Given this list of marker genes PRKAR1B-AS1, C9orf152, MARCHF4, ADAM32, SLC8A3, F5, PLXNB3, PKHD1L1, LINC02284, ADRA2A, P2RY1, CHRFAM7A, GRM3, DNAAF4-CCPG1, ZFP3, ZNF234, GTF2E1, AP1G2-AS1, EREG, TCEAL1, MFAP3L, ZNF543, LINC01331, IL5RA, FKBP1B, WFDC10B, ZNF425, SEPTIN5, INPP5E, CFAP58, INAFM2, RAB27B, MPIG6B, LINC02916 (NCBI Gene Id 124902415), SLC37A1, MMRN1, TNNI3, ACTR5, UPK1A-AS1, MLIP, EFHC2 (EF-hand domain containing 2), PTGS1, RPS6KL1, GP6, RBPMS2, ANKRD20A11P, GK-IT1, CENPS, EGF, PTCRA, PF4, RPL7P7, ANKRD62, EHD3, PTPRK-AS1, MYOM1, LIPC-AS1, ZNF852, PIP5K1C, EFCAB13, EEF2KMT, HOXB-AS2, CLDN2, SUCNR1 (succinate receptor 1), DGKG, LINC01141, ALOX12, TMEM40, ENSG00000227355, NXT2, ITGA2B, ERICH6, RPL31P52 (ribosomal protein L31 pseudogene 52), CNST, RN7SKP16, PCYT1B, PDE6A, ASB2, XYLT2, KLF9, RYR3 (ryanodine receptor 3), NT5M, COL24A1, RAB3C, GP9, ZG16B, RBM15-AS1, PIGP, EYS, LY6G6F, MED12L, CMTM2, MAST1, FAM186B, XIRP2, PEX5, LGALSL, FMO5, TM7SF3-AS1, ABCC3, DGKI, GP1BA, LATS2-AS1, KIAA0513, PRKAR2B-AS1, HPSE, GABRE, PPIF, ITGB3, H2BC4, LINC01786, PTPN23-DT, MLYCD (malonyl-CoA decarboxylase), NRGN, CDK9, LEFTY1 (left-right determination factor 1), LINC01123, PPBP, MTURN, TUBA8, DPY19L2P1, CAPN1-AS1, INTS5, DNAH10, GCSAML, PSPHP1, XRCC2, LINC00534, EXOC3L4, ZNF32, CMTM5, KCNH6, TUBB1, CLEC1B, PADI4, RUFY1, SRPRB, EXOSC5, CXCL3, YTHDF3-DT, SLC39A3, TXNL4B, SELP, RNU6-1228P, PLAC9P1, INHBA-AS1, TTC4, LINC02267, RNU6-469P, MYH7B, ST8SIA6, RNU6-942P, here is a description of the gene set: The gene expression program underlying the specification of human cell types is of fundamental interest. The study authors generated human cell atlases of gene expression and chromatin accessibility in fetal tissues. For gene expression, the study authors applied three-level combinatorial indexing to >110 samples representing 15 organs, ultimately profiling ~4 million single cells. The study authors leveraged the literature and other atlases to identify and annotate hundreds of cell types and subtypes, both within and across tissues. Our analyses focused on organ-specific specializations of broadly distributed cell types (such as blood, endothelial, and epithelial), sites of fetal erythropoiesis (which notably included the adrenal gland), and integration with mouse developmental atlases (such as conserved specification of blood cells). These data represent a rich resource for the exploration of in vivo human gene expression in diverse tissues and cell types. Marker genes curated from the annotated cluster as represented in the Descartes Human Gene Expression During Development database. from publication Cao J, O'Day DR, Pliner HA, Kingsley PD, Deng M, Daza RM, Zager MA, Aldinger KA, Blecher-Gonen R, Zhang F, Spielmann M, Palis J, Doherty D, Steemers FJ, Glass IA, Trapnell C, Shendure J (PMID 33184181) Human Gene Set: DESCARTES_FETAL_KIDNEY_MEGAKARYOCYTES species: Homo sapiens